The following is a description of a gene set: studied in species Homo sapiens Genes up-regulated in B lymphocytes immunized with: imiquimod versus monophosphoryl lipid A and imiquimod. Human Gene Set: GSE25677_R848_VS_MPL_AND_R848_STIM_BCELL_UP Many successful vaccines induce persistent antibody responses that can last a lifetime. The mechanisms by which they do so remain unclear, but emerging evidence suggests that activate dendritic cells (DCs) via Toll-like receptors (TLRs). For example, the yellow fever vaccine YF-17D, one of the most successful empiric vaccines ever developed, activates DCs via multiple TLRs to stimulate pro-inflammatory cytokines. Triggering specific combinations of TLRs in DCs can induce synergistic production of cytokines, which results in enhanced T cell responses, but its impact on antibody responses remain unknown. Learning the critical parameters of innate immunity that programs such antibody responses remains a major challenge in vaccinology. We demonstrated that immunization of mice with synthetic nanoparticles containing antigens plus Toll-like receptor (TLR) ligands 4 (MPL) + 7 (R837) induces synergistic increases in antigen-specific, neutralizing antibodies compared to immunization with a single TLR ligand. To determine whether there was any early programming of B cells, we isolated isotype switched, TCRbeta-CD11b-CD19+IgD-IgG+ B cells by FACS at 7 days post immunization with nanoparticles containing various adjuvants plus OVA, and performed microarray analyses to assess their molecular signatures. from publication Kasturi SP, Skountzou I, Albrecht RA, Koutsonanos D, Hua T, Nakaya HI, Ravindran R, Stewart S, Alam M, Kwissa M, Villinger F, Murthy N, Steel J, Jacob J, Hogan RJ, García-Sastre A, Compans R, Pulendran B (PMID 21350488), and this is the list of marker genes: CNIH2, DUSP21, CD6, MBLAC2, PAFAH2, JAK2, PLCG1, CRADD, ANKRD6, CCND2, PIK3IP1, ADAM9, MATK, MYBBP1A, MAGEL2, CECR2, SSPN (NCBI Gene Id 8082), GBP2, RASSF10, DERL3, CYP24A1, ATOX1, NKX2-6, CD69, SRCIN1, HORMAD1, CYB5R3, OTOA, PKP3, SP5, NDUFA8, PRSS38 (serine protease 38), BET1L, TMEM200C, SEC61B (NCBI Gene Id 10952), RRP1B, PDCD4, ST6GALNAC1, PDZD8, USP35, FEV, PPP1R3E, ASL, LPCAT2, SPAG8, PNPLA2, SLC9C1, FHL3, SYCP1, ELAC1, FOXO1, FAM8A1, HSPA12B, MGLL, TRIM63, PRR19, RETNLB, GPM6A, DUS3L, FLOT1, SPAG7, VSTM2L, DLX2, ABCB11, GABRA2, MAGEA7P, ABCA5, NEFL, PTGER4, TDRD12, GAREM1, MLEC, SLC25A53, MIR155, DDO, NEU2 (NCBI Gene Id 4759), SLC23A3, MLXIP, ODF1, HOXC13, LRRC66, NEU4, LYPD4, ACP5, PEX7, FGF4 (fibroblast growth factor 4), RTKN, CDC20B, ZFP1, KDM6B, TANC1, KCNJ12, OSGIN1, S1PR3, MAP3K5, RAB31, RNF157, PTPN22, ZFP30, NXT2, CNNM4, A1BG, RND3, MED16, SEPSECS, STON1, TRABD, SNORD58B, HBEGF, PSORS1C2, GDF6, HS3ST1, TMEM132A, SLC35G1, DRAM2, METTL17, SLC12A7, DEPDC1, DPYSL4, MRPS26, AQP4, PROKR2 (prokineticin receptor 2), ZFP36L2, NIBAN3 (niban apoptosis regulator 3), RPL15, OLFML1, SERPINF2, LMLN, NOP16, CPA5, PARP12, DCSTAMP, RAPGEF3, DDIT4, GPRC5B, BNC2, XRRA1, FMO4, SERPINH1, SESN1, CUX1 (cut like homeobox 1), GH1, HDDC3